The following is a description of a gene set: species: Homo sapiens An abnormality of the globus pallidus. Human Gene Set: HP_ABNORMAL_GLOBUS_PALLIDUS_MORPHOLOGY Abnormal globus pallidus morphology, and this is the list of marker genes: IDH1, GCDH, PANK2, KMT2B (lysine methyltransferase 2B), CYP2U1, FTL (NCBI Gene Id 93315), FTH1, VPS16, WDR45, CMPK2, SLC44A1, MMUT, NUDT2, COASY, FA2H, NAA60 (N-alpha-acetyltransferase 60, NatF catalytic subunit), POLR2A, DLAT, CYP27A1, AGO1, KCNQ2, VPS41, SLC30A10, IVD (isovaleryl-CoA dehydrogenase), C19orf12, GTPBP2, PLA2G6